Given this list of marker genes Snrpg, Snrpf, Zfp473, Slbp, Lsm11, here is a description of the gene set: Reactome Pathway: SLBP Dependent Processing of Replication-Dependent Histone Pre-mRNAs electronically inferred by orthology from the curated human pathway studied in species Mus musculus This event has been computationally inferred from an event that has been demonstrated in another species.<p>The inference is based on the homology mapping from PANTHER. Briefly, reactions for which all involved PhysicalEntities (in input, output and catalyst) have a mapped orthologue/paralogue (for complexes at least 75% of components must have a mapping) are inferred to the other species. part of: Processing of Capped Intronless Pre-mRNA